The following is a description of a gene set: studied in species Mus musculus Mouse Gene Set: GOCC_INTEGRIN_COMPLEX A protein complex that is composed of one alpha subunit and one beta subunit, both of which are members of the integrin superfamily of cell adhesion receptors; the complex spans the plasma membrane and binds to extracellular matrix ligands, cell-surface ligands, and soluble ligands., and this is the list of marker genes: Itgb8, Itga4, Tspan32, Itgad, Itgb6, Itgb3, Itga8, Itgal (integrin alpha L), Itgb1 (integrin beta 1 (fibronectin receptor beta)), Itga9, Itga2b, Itgbl1, Itgax, Itgb5, Lyn (LYN proto-oncogene, Src family tyrosine kinase), Pmp22, Itga5, Itgb2l, Itga6, Itgb2, Itgae, Itgav, Itgb7, Itga11, Itga7, Itgb4, Plp1, Itga10, Itga1, Emilin1, Itga3, Itgam, Itga2